The following is a description of a gene set: Human Gene Set: chr2p15 species: Homo sapiens, and this is the list of marker genes: RPS20P9, C2orf74-AS1, RPL27P5, RSL24D1P2, SANBR, XPO1, TMEM17, RPL21P37 (NCBI Gene Id 100129141), PRELID1P6, COMMD1, RPL27P6, ENSG00000289410, RPS4XP5, EHBP1-AS1, RPS29P10, MTFR2P1, PUS10, RPSAP26, C2orf74 (chromosome 2 open reading frame 74), CSP1, UGP2, B3GNT2, USP34-DT, USP34, RPL31P30, OTX1, ENSG00000229839, RPL37P13, RN7SL18P, DBIL5P2, MDH1, RNU6-1145P, ENSG00000302408, WDPCP, RN7SL51P, RPS24P7, BNIP3P45, CCT4, AHSA2P, PEX13, MIR5192, PSAT1P2, SNORA70B, HNRNPA1P66, FAM161A (FAM161 centrosomal protein A), EHBP1